Given this list of marker genes NKAIN1, MIR7-3HG (MIR7-3 host gene), PPM1N, ADGRB3, LARS1, CYB5R4, SCRT1, MXD3, AP3B2, CELF6, SRRM3, SVOP, HTR5A, SRSF2, RHNO1, MFSD11, VWA5B2, SNAP25-AS1, NCAPG, SYT5, BARHL1, MT-TT, HMGB2, MTCO3P12, DUT-AS1, CDKN2D, SLC8A2, MAPK8IP2, MT-CYB, CDCA4, GIT1, FAM111A, HMGN2, TULP3, LINC01596, UBE2V1P4, MIR7-3, VGF, GLRA1, CA11, RNA5SP60, MIR1224, KCNIP1-AS1, NEUROD4, MAPK11, NBPF1, WASF2, LINC02142, FOXM1, MT-ND6, DUT, MT-TE, DCAF16, OGDHL, YIF1A, here is a description of the gene set: Genes containing one or more binding sites for (ASXL2) in their promoter regions (TSS -1000,+100 bp) as identified by GTRD version 20.06 ChIP-seq harmonization. from publication Yevshin I, Sharipov R, Kolmykov S, Kondrakhin Y, Kolpakov F (PMID 30445619) Human Gene Set: ASXL2_TARGET_GENES species: Homo sapiens